The following is a description of a gene set: Human Gene Set: GOCC_BASEMENT_MEMBRANE studied in species Homo sapiens A collagen-containing extracellular matrix consisting of a thin layer of dense material found in various animal tissues interposed between the cells and the adjacent connective tissue. It consists of the basal lamina plus an associated layer of reticulin fibers., and this is the list of marker genes: FREM1, MATN2, FBN1, CCDC80, TINAG, RELL2, LAMB4, ACHE, COL22A1, COL17A1, DAG1, COLQ, NID2, NID1, NTN4, VWA2, DST, COL28A1, LAMA4, LAMA5, TIMP1, SPN, COL13A1, SERPINF1, LAMB2, VWA1, COL4A5, COL4A3, TGFBI, APLP1, NPNT, COL4A6, LAMB1, CASK, SMOC1, FRAS1, AMELX, MMRN2, LAMB3, COL6A1, LOXL2, SPARC, TNC, AMTN, COL16A1, LAMC3, COL4A2, HMCN2 (NCBI Gene Id 727754), COL8A2, HSPG2, ACTA2, COL2A1, SMOC2, ADAMTS1, LAMC1, ANG, ANXA2P2 (annexin A2 pseudogene 2), COL7A1, ERBIN, EFEMP2, DLG1, COL8A1, HMCN1, COL15A1, COL4A1, TIMP3, COL24A1, LAMC2 (NCBI Gene Id 3918), EGFL6, COL5A1, USH2A, COL4A4, ITGB4, ENTPD1, FREM3, LAMA1, ANXA2, MEGF9, THBS4, PXDN, AGRN, LAD1, FREM2, NTN1, THBS2, EGFLAM, FBLN1, FN1, VTN, LAMA2, ENTPD2, EFNA5, LAMA3, P3H2, COL18A1, COL9A3, VWC2, LOXL1, CD151